Given this list of marker genes AMIGO2, AK5, SRPX2, SH2D1B, SPATA18, CDCP1, IFITM1, IFITM2, PRDX6, PLOD2, HLA-DMA, NDRG4, ENO2, MIA, MX1, GBP3, PDGFRL, SLCO2A1, SMARCA1, SHISAL1, HLA-B, EMILIN2, IGFBP7, CDCA7, PTGR1, CEND1, CCL20, TTYH2, HIF1A, SGPL1, TAGLN, COMMD8, CHST15, SHLD1, SMOX, TMEM45A, PYGB, ANXA6, PLCB4, DAAM2, SEPTIN6 (septin 6), DEPTOR, STK38, PAGE1, NNMT, IQCK, APMAP, TMCO4, IL32, B3GALNT1, CD83, S100A2, RAB20, IL1R1, DNAJC22, SCNN1A, AOPEP, LMBR1L, NAA20, DSTN, HCLS1, ALPK2, HTRA3, EFEMP2, CCN2, PDLIM1, TPM3, JAG1, LAMA4, HHIP, MACROH2A1, ANKDD1A, COL6A2, SERPINH1, HEG1, MKKS, SLAMF7, WDR46, HSD11B1, DOK1, TNFRSF11B, NXN, SERPINA5, PTGS1, ALDOC, EFEMP1, TIMP3, RGS4, POLR2M, ANXA7, NR3C1, FUCA1, CA12, LPXN, LHPP, STK3, COL18A1, TPST2, KRT86, ERO1A, ENPP1, NFE2L3, DDIT4, PPARG, SNAP25, LRRN4CL (NCBI Gene Id 221091), MYLK, PNKD, ITM2A, CNEP1R1, PXDN, N4BP2L1, PAEP (NCBI Gene Id 5047), COL4A2, APOL3, IL2RB, NNT, LGALS3BP, TRIML2, HSD17B6, IGFBP2, MSX1, PIK3IP1, ATF7IP2 (activating transcription factor 7 interacting protein 2), CXXC5, ANGPTL2, NR1H3, XRN2, MRPS26, TMEM74B, CCND2, PLK2, SULF2, SOD3, LGMN, ZG16B, HMGN1, OAS1, SNX10, TMEM98, NUPR1, BACE1, LYPD6B, RBFOX2, SIRPA, LOXL3, GJB2, HERPUD1, PIK3CD, PAQR6, RBPMS2, SNX5, ISG20, ATP5MK, PPP6R2, FST, PSD4, ADGRE1, IL4I1, MUC6, MDK, TDO2, PYCARD, GPR55, LAMB1, FN1, C1QTNF6, MAGED4B, NMNAT2, ADORA2A, CSNK2A1, PMAIP1, CGNL1, FKBP7, FKBP1A, SUSD4, PLAC8, TLR2, NCF2, H2BC5, CRLS1, CALD1, ARRDC4, NCAM1, CYTL1, FLI1, P3H1, KIF1B, ICAM2, BTG2, SOBP, RCC1, DHX40, QPRT, GMFG, DENR, MOCOS, UACA, COL5A1, SLC16A4, CHSY1, LRIG1, KDM1A, MEGF10, ARHGAP36 (Rho GTPase activating protein 36), ST6GAL1, RIN2, LRP5, COLEC12, TMEM44, LRRC17, PNPLA7, N4BP2L2, FRMD6, GLIPR1, PCOLCE, ALDH18A1, MYO18B, DDX43, NKD2, VANGL2, HAS2, HLA-DMB, CACNG6, MYLK2, PRAG1, COL6A1, DAPK1, ADD3, GPR162, CSPG4, MATN2, MRPL42, HBE1, CDC42, SLC12A7 (NCBI Gene Id 26129), PLAAT3, CST7, IL1R2, TAF12, TXNIP, FOXN3, COL4A1, ERRFI1, TMEM59L, MYRF, FCRLA, ECHDC2, MMP14, HLA-DPB1, TRPV4, MAGEC2, SNRPB2, CPE, BOC, WDR86, PLAAT4, PALM2AKAP2, TPM1, RWDD2B, FEZ1, PYROXD2, SHROOM2, PLXND1 (plexin D1), H4C14, ADA, ANKRD1, here is a description of the gene set: species: Homo sapiens from publication Rozanov DV, Savinov AY, Williams R, Liu K, Golubkov VS, Krajewski S, Strongin AY (PMID 18519667) Genes up-regulated in HT1080 cells (fibrosarcoma) over-expressing MMP14 compared to those with knockdown of the gene by RNAi. Invasion-promoting MT1-MMP is directly linked to tumorigenesis and metastasis. Our studies led us to identify those genes, the expression of which is universally linked to MT1-MMP in multiple tumor types. Genome-wide expression profiling of MT1-MMP-overexpressing versus MT1-MMP-silenced cancer cells and a further data mining analysis of the preexisting expression database of 190 human tumors of 14 cancer types led us to identify genes, the expression of which correlated firmly and universally with that of MT1-MMP (P < 0.00001). These genes included regulators of energy metabolism (NNT), trafficking and membrane fusion (SLCO2A1 and ANXA7), signaling and transcription (NR3C1, JAG1, PI3K delta, and CK2 alpha), chromatin rearrangement (SMARCA1), cell division (STK38/NDR1), apoptosis (DAPK1), and mRNA splicing (SNRPB2). Our subsequent extensive analysis of cultured cells, tumor xenografts, and cancer patient biopsies supported our data mining. Our results suggest that transcriptional reprogramming of the specific downstream genes, which themselves are associated with tumorigenesis, represents a distinctive molecular signature of the proteolytically active MT1-MMP. We suggest that the transactivation activity of MT1-MMP contributes to the promigratory cell phenotype, which is induced by this tumorigenic proteinase. The activated downstream gene network then begins functioning in unison with MT1-MMP to rework the signaling, transport, cell division, energy metabolism, and other critical cell functions and to commit the cell to migration, invasion, and, consequently, tumorigenesis. Human Gene Set: ROZANOV_MMP14_TARGETS_UP